Given this list of marker genes GNRH1, GPHB5, FSHB, TSHB, CGA, LHCGR, GNRHR2, GPHA2, GNRHR, TSHR, FSHR, GNRH2, LHB, here is a description of the gene set: species: Homo sapiens Reactome Pathway: Hormone ligand-binding receptors The class A (rhodopsin-like) GPCRs that bind to hormone ligands are annotated here. The hormones follicle-stimulating hormone (FSH), luteinizing hormone (LH), thyroid-stimulating hormone (TSH) and human chorionic gonadotrophin (hCG) are dimeric glycoproteins, sharing an identical alpha subunit and varying beta subunits. Their actions are mediated by the respective GPCRs, influencing reproductive processes and thyroid hormone release. part of: Class A/1 (Rhodopsin-like receptors)